Given this list of marker genes C1qa, C1s2, C1ra, C1qb, C1qc, Igll1, here is a description of the gene set: This event has been computationally inferred from an event that has been demonstrated in another species.<p>The inference is based on the homology mapping from PANTHER. Briefly, reactions for which all involved PhysicalEntities (in input, output and catalyst) have a mapped orthologue/paralogue (for complexes at least 75% of components must have a mapping) are inferred to the other species. Reactome Pathway: Classical antibody-mediated complement activation electronically inferred by orthology from the curated human pathway species: Mus musculus part of: Creation of C4 and C2 activators